Given this list of marker genes PLG, DHCR7, BMP4, ANG, MAPK14, here is a description of the gene set: The von Hippel-Lindau tumor suppressor pVHL regulates the stability of hypoxia-inducible factors (HIF)-1 and -2, oxygen-sensitive basic helix-loop-helix transcription factors, which mediate the hypoxic induction of angiogenic growth factors such as vascular endothelial growth factor. Loss of pVHL function results in constitutive activation of HIF-1 and HIF-2 and is associated with the development of highly vascularized tumors in multiple organs. We have used a conditional gene-targeting approach to investigate the relative contributions of HIF-1 and HIF-2 to VHL-associated vascular tumorigenesis in a mouse model of liver hemangiomas. Here we demonstrate genetically that conditional inactivation of HIF-2alpha suppressed the development of VHL-associated liver hemangiomas and that angiogenic gene expression in hepatocytes is predominantly regulated by HIF-2 and not by HIF-1. These findings suggest that HIF-2 is the dominant HIF in the pathogenesis of VHL-associated vascular tumors and that pharmacologic targeting of HIF-2 may be an effective strategy for their treatment. Angiogenic genes up-regulated in hepatocytes after knockout of VHL and HIF2A. Human Gene Set: RANKIN_ANGIOGENIC_TARGETS_OF_VHL_HIF2A_UP from publication Rankin EB, Rha J, Unger TL, Wu CH, Shutt HP, Johnson RS, Simon MC, Keith B, Haase VH (PMID 18490920) studied in species Mus musculus